The following is a description of a gene set: Any complex that possesses RNA polymerase activity; generally comprises a catalytic subunit and one or more additional subunits. Human Gene Set: GOCC_RNA_POLYMERASE_COMPLEX studied in species Homo sapiens, and this is the list of marker genes: ERCC2, GTF2H2C_2, MYZAP, TAF6, TAF11L9, POLR1D, PEX2, POLR2F, MMS19 (MMS19 homolog, cytosolic iron-sulfur assembly component), CRCP, ENY2, POLR2E, USP22, CCNH, TAF1, TAF11L4, POLR2D, GTF2A1L (general transcription factor IIA subunit 1 like), POLR3B, POLR3G, TUFT1, POLR3A, GTF2A2, GTF2E2, TAF8, POLR1H, POLR1G (NCBI Gene Id 10849), TCEA1, GTF2H2C, POLR1A, POLR2L, PRIMPOL, GTF2A1, GTF2H1, TAF11L7, TAF7, TBP, GTF2H5, TERT, RPAP1, TAF11L12, TENT2, TAF11L10 (NCBI Gene Id 112488738), POLR1C, PAF1, TRRAP, GTF2H2, TADA3, ZNFX1, TAF10, CTR9, POLR1F, POLR3GL, POLR3D, TAF11L6, RTF1, CDC73, GTF2E1, TAF13, POLR2I, TAF9B, MNAT1, TAF11L3, TAF11L2, ERCC3, POLR3K, KAT2A, SUPT3H, TAF3, POLR2B (NCBI Gene Id 7890), TAF4B, LEO1, CDK7, ATXN7L3, POLR2A, PRIM2, POLR2G, POLA2, TAF5 (NCBI Gene Id 6877), TAF9, POLR2J2 (NCBI Gene Id 246721), ATXN7, GTF2H3, POLRMT, POLR3F, POLR3C, TAF4, PRIM1, TAF11L13, TBPL1 (NCBI Gene Id 9519), POLR1B, POLR1E, GTF2H4, POLR2H, GTF2F2 (NCBI Gene Id 2963), POLA1, POLR2M, POLR2K, GTF2B, TAF2, POLR3H (NCBI Gene Id 91605), MCM3, TAF1L, GTF2F1, TAF5L, POLR2J, TAF11L11, POLR2C, TAF11L8, TAF7L, PAAF1, TAF11, POLR2J3, POLR3E, TAF12 (TATA-box binding protein associated factor 12), TAF6L, TAF11L14, SKIC8